Given this list of marker genes Klrc2, Trim65, Gm12250, Neurl3, Leprotl1, Gbp4, Gbp2b, Irgm2, Calhm6, Slamf8 (SLAM family member 8), Gpr174, Ccl4, Trbv31, Gbp10, Nlrc5, Lair1, Cd8a, Aif1 (allograft inflammatory factor 1), P2ry10, Gbp8, Ccm2, Cd27, Trbv17, Gvin-ps1, Tlr12, H2-M3, Gm2427, H2-Ab1, H2-T11-ps, Trac, H2-T22, Il27, Fcgr4, Ighd, Tap1, Sla2, H2-T15, H2-T7, Gm8810, Psap, B2m, Dusp2, Ralgps2, Klrc1, H2-T3, Clec12a, Plek, Slc15a3, Art2a, Ccl8, Klrk1, H2-K2, H2-DMa (histocompatibility 2, class II, locus DMa), Satb1, Pdcd1, Serping1, Rnf145, Sh2d2a, Ighm, Gvin-ps6, H2-T10, Tapbpl, Stat1, H2-Eb1, Gbp3 (NCBI Gene Id 99898), H2-Q10, Ifngr2, H2-Ea (NCBI Gene Id 14968), H2-Q2, Gbp11, Nkg7, Il18bp, Trav7d-4, Fasl, Lag3, Ly6i, Tgtp2, C1qb, Dnase1l3, Psmb9, Slc17a6, Psmb8, H2-D1, Crtam, Igtp, Ccr8, H2-Aa, Usf1, AW112010, Il10, Tnfrsf4, Itk, Fgl2, Gm19585, H2-DMb1, Gbp6, Gbp2, Ubd, Tmem51, Crem, Slc11a1, Tgtp1 (NCBI Gene Id 21822), Il21r, Mag (NCBI Gene Id 17136), C4a, Tent5c, Izumo1r, C6, Tmem229b, H2-Q1, C4b, Etohd2, here is a description of the gene set: from publication Zemek RM, De Jong E, Chin WL, Schuster IS, Fear VS, Casey TH, Forbes C, Dart SJ, Leslie C, Zaitouny A, Small M, Boon L, Forrest ARR, Muiri DO, Degli-Esposti MA, Millward MJ, Nowak AK, Lassmann T, Bosco A, Lake RA, Lesterhuis WJ (PMID 31316010) studied in species Mus musculus The authors compared the cellular composition and gene expression profiles of responsive and nonresponsive tumors from BALB/cArc, BALB/cJAusb, and C57BL6/J mice before immune checkpoint blockade (ICB) and validated the findings in cohorts of patients with cancer treated with ICB antibodies. Mouse Gene Set: ZEMEK_IMMUNE_CHECKPOINT_BLOCKADE_OVARIAN_CANCER_OVERLAP_UP Experiments were performed using AB1 mesothelioma and Renca renal cell carcinoma cell lines.